Given this list of marker genes Lpl, Bax, Bcl2a1a, Il1b, Sdc4, Glrx, Cdkn1a, Ran, Clec4n, Atp6v1b2, Dok2, Atp6v0a1, Ccl9, Srm, Bcl2a1b, Prkcd, Eef1e1, Eif5a, Serpina3g, Scimp, Mrpl11, Ccl2, Serbp1, Ncl (nucleolin), Cd209e (NCBI Gene Id 170780), Set, Bcl2a1d, Ccl12, Fth1, Tma16, Tubb6, Pfn1, Lrrc59, Basp1, Ranbp1, Gtpbp4, Nabp1, Odc1, Anp32b, Eif4g2, Imp4, Palld, Nlrp3, Ccl7, Plek, Ptpn1, Ccl6, Riok3, Eif4a1, here is a description of the gene set: species: Mus musculus from publication Cui A, Huang T, Li S, Ma A, Pérez JL, Sander C, Keskin DB, Wu CJ, Fraenkel E, Hacohen N (PMID 38057668) Cytokines mediate cell-cell communication in the immune system and represent important therapeutic targets. A myriad of studies have highlighted their central role in immune function, yet we lack a global view of the cellular responses of each immune cell type to each cytokine. To address this gap, the authors created the Immune Dictionary, a compendium of single-cell transcriptomic profiles of more than 17 immune cell types in response to each of 86 cytokines (>1,400 cytokine-cell type combinations) in mouse lymph nodes in vivo. A cytokine-centric view of the dictionary revealed that most cytokines induce highly cell-type-specific responses. For example, the inflammatory cytokine interleukin-1β induces distinct gene programmes in almost every cell type. A cell-type-centric view of the dictionary identified more than 66 cytokine-driven cellular polarization states across immune cell types, including previously uncharacterized states such as an interleukin-18-induced polyfunctional natural killer cell state. Genes positively differentially expressed in cell type: Macrophage upon treatment with cytokine: GM-CSF in mouse lymph nodes in vivo. Mouse Gene Set: CUI_MACROPHAGE_GM_CSF_RESPONSE_UP